Given this list of marker genes ZNF445, MECP2, WT1, MBD1, MACROH2A1, EGR1, here is a description of the gene set: Binding to double-stranded methylated DNA. Methylation of cytosine or adenine in DNA is an important mechanism for establishing stable heritable epigenetic marks. studied in species Homo sapiens Human Gene Set: GOMF_DOUBLE_STRANDED_METHYLATED_DNA_BINDING